The following is a description of a gene set: Mouse Gene Set: TABULA_MURIS_SENIS_TRACHEA_T_CELL_AGEING studied in species Mus musculus from publication Tabula Muris Consortium (PMID 32669714), and this is the list of marker genes: Trabd, Myl12a, Polr2c, Tmem59, Gfer, Rbm25, Spp1, Riok1, Unk, Mrpl15, Ubl7, Mrpl12, Aasdhppt, Nle1 (notchless homolog 1), Mpc2, Adprh, Pold4, Trappc6a, Rala, Larp1b, Pfn1, Rnf138, Polr3b, Zfp182, Thoc7, Ociad1, Socs1, Ubr2, Ankrd11, Kdelr1, Bcl7c, Dctn6, Asxl2 (ASXL transcriptional regulator 2), Ppp1r35, Lrrc40, Gcg, Mrps12, Adissp, Oxsr1, Adrm1, Calm1, S100a6, Jund, Mpc1, Arb2a, Btbd1, Dtx3, Denr, Actr10, Krt8, Exosc5, Espn, Bcl7a, Ahnak, Nt5c, Arhgdia, Smco4, Ssbp3, Aspn, Ppib, Lime1, Polr2a, Avpi1, Naa35, Smim14, Senp6, Zfp689, Thoc6, Gnb1, Rab43, H2ac13, Fance, Arpc1b, Ubl4a, Pym1, Prr7, Arhgef6, Eif1b, Mafg, Yipf3, Dok2, Mrpl9, Sf3b2, Dmac1, Eif3f, Trmt10c, Ngdn, Iapp, Ccdc107, Rab24, Smim13, Vasp, Trappc3, Sp2, Suds3, Ifnar2, Spred2, Cap1 (cyclase associated actin cytoskeleton regulatory protein 1), Crk, Il21r, Gpalpp1, Mix23, Nt5c3b, Rabac1, Kxd1, Bcl2a1b, Cfl1, Fkbp2, Bmp7, Socs4, Rnaset2b, Vps72, Ino80dos, Kpna4, Rab5c, Triap1, Mideas, Nmt2, Azi2, Cyba, Gtf2b, Tsc22d3, Ubald1, Pdap1, Sphk2, Eed (embryonic ectoderm development), Dstyk, Lsp1, Nr2c2ap, Ubb-ps, Urb1, Rapgef1, Aak1, Gadd45gip1, Cyth2, Ccsap, Srp9, Med9, Pcmtd1, Lgals1, Ankrd26, H2-K1, Mrpl45, Laptm4a, Wnk1, Tob2, Snrnp48, Larp7, Gimap1, Capns1, Ube2k, Taf11, Epc1, Polr3k, Uba5, Nup50, Txndc9, Polr3e, Nr1h2, Cit, Hmg20b, Pebp1, Gtf3c3, Tpst2, Ddx19a, Obi1, Abhd8, Hnrnph3, Pdcd1, 1700113A16Rik, Prickle1, Cd82, Lef1 (lymphoid enhancer binding factor 1), Rabl6 (RAB, member RAS oncogene family-like 6), AA465934, Cela2a, Ap2s1, Npc2, Wee1, Zfp330, Ptprcap, Ykt6, Armc7, Ccdc12, Adprs, Ep400, Tex261, Pin1, Taf13, Dnajc19, Scp2, Zfp386, Gabarap, Adck5, Cdk2ap2, 6820431F20Rik, Junb, Glrx, Thap7, Disp1, Tmsb10, Tysnd1, Ins2, Zwint, Prdx5, Rpl13a, Trappc6b, Pigf, Pdxk, Ccdc28a, Sh3gl1, Cd40lg, Ppie, Syvn1, Snrpc, Sec11a, Mycbp2, H2-D1, Baz1a, Mrps26, Gps2, B3gat3, Tle5, Rnf11, Pxmp4, Spr, Rnaseh2c, Gar1, Crbn, Maz, Ppp1r12a, Tprkb, Tfpt, Nabp2, Herc6, Tti2, Drap1, Emc10, Wdr45, Trir, Fam204a, Szrd1 (NCBI Gene Id 52069), Zrsr2, Mpv17l2, Jagn1, Abtb2, Lyz2, Nfkbib, Gtf3c1, Ogt, Usp48, Palm (paralemmin), Mlf2, Abt1, Hras, Tprg1l, Ino80e, Rbm42, Nat10, Gtf2h2, Prr13, Fmnl1, Tnks, Atp6v0c, Cdc23, Ing2, Ocel1, Mboat7, Chga, Cenpo (NCBI Gene Id 76550), Chd1, Tmem160, Zmat2, Secisbp2, Tnrc6a, Sdhaf2, Slc14a1, Mbp, Tmem222, Acp5, Dedd2, Itm2b, Ehmt1, Hcls1, Lat, Kmt2b, Rap1a, Phf23, Bod1l, Nsd3, Vcf1 (VCP nuclear cofactor family member 1), Flot2, Lias, Elmo1, Ins1, Fth1, Irf2, Ube2j2, Apbb1ip, Inpp1, Nsa2 (NSA2 ribosome biogenesis homolog), Trappc4, Mef2d, Prmt1, Nip7, Il7r, Cdc42ep3, Orai1, Dock10, Isg20l2, Akr1a1, Cds2, S1pr4, Rpap1, Map1lc3a, Tmed9, Arpc4, Gch1, Trmt13, Gimap9, Fxyd5, Rnf5, Rp9, Cdc37, Cep57l1, Cd37, Spry1, Selenok, Pole4, Taf4b, Bsg, Prpf18, Vim (vimentin), Hectd1, Ssbp1, S100a4, Abi3, Ccnd2, Gpaa1, Ralgapa1, Ndufs4, Ncor1, Mfsd5, Fntb, Pum1, Yipf5, Mrpl2, Flt3l, Nr4a3 (NCBI Gene Id 18124), Zmynd19, Arhgef7, Cdc37l1, Pdcd10 (NCBI Gene Id 80414), Rab10os, Thoc2, Cerk, Dgcr8, Gzma, Polr2g, Dohh, Grcc10, Dync1i2, Tdp2, Rbm5, Sema4d, Rchy1, Zcchc17, Krt83, Rmi2, Elof1, Frg1 (NCBI Gene Id 14300), Pfdn6, Acap2 (NCBI Gene Id 78618), Prrc2b, Fam89b, Eno1b (enolase 1B, retrotransposed), Gemin7, Syf2, Ypel3, Sgf29, Rrp36, Ube2m, Psmd4, Dynll2, Abca2, Rps6kb2, Rtf1, Ccdc71l, Max, Necap2, Ppp1r10, Znhit1, Gga1, Rpap3, Tmem50a (NCBI Gene Id 71817), Rnf126, Uggt1, Polq, Ech1, BC004004, H3c1, Ubxn4, Bex3, Rbm33, Ssbp4, Bag1, Tbcc, Sdad1, 1700123O20Rik, Cdc42se1, Aarsd1, Tagln2, Tmem181a, Ino80b, Utp11, Npm3, Emd, Alg5 (ALG5 dolichyl-phosphate beta-glucosyltransferase), Tmed10, Cep70, Chmp4b, Maf1, Ostf1, Fus, Sf3b4, Yy1, Mrps24, Tut4, Fbxl12, Sdhc, Commd7, Tmx2, Mmp24os1, Gsn, Hsd17b8, Plekhj1, Vps28, Gtf2ird1, Cirbp